Given this list of marker genes Stx12, Clstn1, Snx1, Tfrc, Abhd17b, Akap5, Anp32e, Gripap1, Kif21b, Abhd17a, Nsg1, Rab11a, Arc, Mkln1, Pick1, Zdhhc2, Rab4a, Rab5a, Snx27, Vps26b, Snx6, Myo5b, Pik3c3, Eea1, Rab11fip3, Ap3m1, Sh3gl3, here is a description of the gene set: studied in species Mus musculus Mouse Gene Set: GOCC_POSTSYNAPTIC_ENDOSOME An endosomal compartment that is part of the post-synapse. Only early and recycling endosomes are typically present in the postsynapse.